Given this list of marker genes RNF19A, NTRK3, SNX2, COLCA1, SKAP2 (src kinase associated phosphoprotein 2), CEP15, SGIP1, DENND4C, CFAP126, SCCPDH, HHEX, RNF157, FCRL1, BCL6, ABAT, JAK2, LY96, SNX8, DCUN1D4, GFI1, KLHL4, TRIM36, TTC16, STXBP1, VAMP5, TTLL5, ZC4H2, RNF128, EGLN3, JDP2, GGT7, TOR2A, RDH12, POU2AF1, DHRS3, SLC11A2, ABCB9, CEBPA, COPRS, PPP1R16B, VIPAS39, GPR137B, TUSC2, OTUD7B, CASP4, PLA2G15, TNC, AGPAT3, C1QTNF4, UBAC2, TMEM140, PLAAT3, NRGN, HCFC2, NADK2, GALNT2, EVI2A, PTPN5, SLC45A4, IKZF2, SLC22A15, GZF1, PRKAG3, CTSB, OTUB2 (OTU deubiquitinase, ubiquitin aldehyde binding 2), EPDR1, SYDE1, PAIP2, RNASET2, ZFP41, OSBPL6, PRXL2B, DYNLT3 (dynein light chain Tctex-type 3), BAZ1A, SMCO4, TXLNB, SQOR, ANG, MGRN1, HMOX1, LYL1, TIRAP, MAN2A1, RBMS2, CFAP157, HSF4, RABGAP1L, SLC26A11, CLCN5, SPTBN2, IFT43, PLD1, LPP, CORO2B, CST7 (cystatin F), ATP6V0D1, RYR1, RYR3, TUBB2B, CMSS1, AREL1, S100A11, CRAT, CBR4, DOCK6 (dedicator of cytokinesis 6), MAPRE2, ISG20, BET1, NFATC1, CACNA1S, KRT85, ECHDC3, MEF2B, TASP1, TMED8, CD300LB, SLAMF6, IL21 (interleukin 21), ADAMTS3, STK39, ANGPTL2, KRT222, PTRH1, SETD4, CYB5D2 (cytochrome b5 domain containing 2), ZNF76, SIX5, NDNF, RGCC, CYSLTR2, PBX3, FAS, MYO18A, KSR1, SNX10, ZMAT3, KIAA0753, PITPNM2 (phosphatidylinositol transfer protein membrane associated 2), SORD, GSTM4, UMAD1, ST6GALNAC1, CRPPA, CDK5R1, ASAP2, VSIR, IL4, SLC46A1, HAP1, ATOSA, TOR4A, OAZ2, SLC43A1, SERINC5, PPP3CC, TMEM38B, CD160, MMD (monocyte to macrophage differentiation associated), TTC8, DCAF7, LRRC72, CELA1, MPP1, ARFGAP3, SGSH, PDE3B, DHCR7, EIF4ENIF1, FRMD4B, SENP8, FYN, CXCL10, KCNA3, POGLUT3, BMP2K, ANXA3, DDX28, LMO4, GDPD5, SLC9A9, BMAL1, SH3RF1, TMEM86A, SNAI2, FAM241B, ZNF518B, TLR6, HNRNPLL, CPEB1, ADPRM, FAM43A, PXMP4, PTPN13, TRPM6, LAMP2, SAMSN1, CXCR5, here is a description of the gene set: Active suppression of tumor-specific T lymphocytes can limit the immune-surveillance and immunotherapy efficacy. While tumor-recruited CD11b+ myeloid cells are known mediators of tumor-associated immune dysfunction, the true nature of these suppressive cells and the fine biochemical pathways governing their immunosuppressive activity remain elusive. Here we describe a population of circulating CD11b+/IL-4Rα+, inflammatory-type monocytes that is elicited by growing tumors and activated by IFN-γ released from T lymphocytes. CD11b+/IL-4Rα+ cells produce IL-13 and IFN-γ and integrate the downstream signals of these cytokines to trigger the molecular pathways suppressing antigen-activated CD8+ T lymphocytes. Analogous immunosuppressive circuits are active in CD11b+ cells present within the tumor microenvironment. These suppressor cells challenge the current idea that tumor-conditioned immunosuppressive monocytes/macrophages are alternatively activated. Moreover, our data show how the inflammatory response elicited by tumors has detrimental effects on the adaptive immune system and suggest novel approaches for the treatment of tumorinduced immune dysfunctions. studied in species Homo sapiens Human Gene Set: GSE5455_HEALTHY_VS_TUMOR_BEARING_MOUSE_SPLEEN_MONOCYTE_UP Genes up-regulated in ITGAM+ cells from spleen: healthy versus tumor bearing mice. from publication Gallina G, Dolcetti L, Serafini P, De Santo C, Marigo I, Colombo MP, Basso G, Brombacher F, Borrello I, Zanovello P, Bicciato S, Bronte V (PMID 17016559)